Given this list of marker genes KPNA2, CAMK2G, CREB1, CAMK2D, CAMKK2, CALM1, CAMKK1, CAMK4, CAMK2B, CAMK2A, here is a description of the gene set: CaMK IV-mediated phosphorylation of CREB Human Gene Set: REACTOME_CAMK_IV_MEDIATED_PHOSPHORYLATION_OF_CREB studied in species Homo sapiens